The following is a description of a gene set: Genes down-regulated in dendritic cells: immature versus mature inhibitory infected with L. monocytogenes. from publication Popov A, Driesen J, Abdullah Z, Wickenhauser C, Beyer M, Debey-Pascher S, Saric T, Kummer S, Takikawa O, Domann E, Chakraborty T, Krönke M, Utermöhlen O, Schultze JL (PMID 18802101) studied in species Homo sapiens Myeloid dendritic cells (DC) and macrophages play an important role in pathogen sensing and antimicrobial defense. Recently we demonstrated that infection of human DC with intracellular bacterium Listeria monocytogenes (L.monocytogenes) leads to the induction of the immunoinhibitory enzyme indoleamine 2,3-dioxygenase (Popov et al., J Clin Invest, 2006), while in the previous studies L.monocytogenes infection was associated with a rather stimulatory DC phenotype. To clarify this discrepancy we performed comparative microarray analysis of immature mo-DC (immDC), mature stimulatory mo-DC (matDC) and mature inhibitory DC either stimulated with prostaglandin E2 (PGE2-DC) or infected with L.monocytogenes (infDC). Studying infection of human myeloid DC with Listeria monocytogenes, we found out, that infected DC are modified by the pathogen to express multiple inhibitory molecules, including indoleamine 2,3-dioxygenase (IDO), cyclooxygenase-2, interleukin 10 and CD25, which acts on DC as IL-2 scavenger. All these inhibitory molecules, expressed on regulatory DC (DCreg), are strictly TNF-dependent and are in concert suppressing T-cell responses. Moreover, only DCreg can efficiently control the number of intracellular listeria, mostly by IDO-mediated mechanisms and by other factors, remaining to be identified. Analyzing publicly acessible data of transcriptional changes in DC and macrophages, infected by various pathogens and parasites (GEO, GSE360), we noticed that infection of these cells with Mycobacterium tuberculosis causes transcriptional response, comparable with the one caused by listeria in human DC. In fact, granuloma in tuberculosis and listeriosis in vivo are enriched for myeloid DC and macrophages characterized by regulatory phenotype. In summary, regulatory myeloid DC and macrophages may play a dual role during life-threatening granulomatous infections, such as tuberculosis: on one hand, regulatory myeloid cells promote pathogen containment by efficiently killing intracellular bacteria, on the other hand these cells inhibit granuloma-associated T cells and thereby might be involved in the retention of TNF-controlled granuloma integrity protecting the host from granuloma break-down and pathogen dissemination. Human Gene Set: GSE9946_IMMATURE_VS_LISTERIA_INF_MATURE_DC_DN, and this is the list of marker genes: RDH5 (NCBI Gene Id 81991), HTR6, CDK5R2, RGR, EGFL6, VAMP7, KCNK13, MGST1, TPPP2, RTN4R (reticulon 4 receptor), SLC16A14, BCL2L14, FIBIN, PDE5A, MIR543, MYOF, TMEFF1, OSGEPL1 (O-sialoglycoprotein endopeptidase like 1), NUP160, SERPINB12, RGS18, FGF6, SLC35A2, HMGN3, THNSL2, TCEAL8, TMEM164, PROCA1 (protein interacting with cyclin A1), HOXC10, TBC1D5, SLC37A1, MESP1, TPI1, MRS2, PLXNB3, TRIM72, TNNT1, GEMIN8, MIR7-1, MICAL2, GYS2, RNF13 (ring finger protein 13), SCN11A, UIMC1, MIR1-1, DRAM2, FBXO4, GNG2, AOC3, ADGRG2, NHLRC1, FAM169A, MARCHF1, SSC4D, BTRC, CDH12, EEF1AKMT2, PAQR3, RAB3GAP2, ALG8, MIR653, FRMD3, GRB7, ISG20, AHDC1, CYFIP1, PSMB11, BTF3, ASB11, AMPH, IK, ASB2, LGI2, RBM15, CTH, RAD50, TMEM82 (NCBI Gene Id 388595), RPS14, PIK3AP1, PLA2G12B, BMP6, APOL6, KRTAP26-1, PABPC4, ESM1, GYPA, MTHFD2L, IFITM3, GPX2, RTKN, PTGS1, ENTPD1, HOXA9, POU2AF1, CYP2R1, MTREX, OXSM, CLCN1, C1QL4, CCDC184, COX20, IL22RA2, FER1L4, ALDH1L2, TMEM165, BCAP29, ADCYAP1, TRIM24, SLC35F1, ACE, VLDLR, CCDC141, SDC4, MRPL49, ASCC2, UPK3B, CENPC (NCBI Gene Id 1060), NRP1, CLU, PTGR3, KLHL23, SEC14L3, GPN1, USPL1, ASAH2, GAP43, RBPJ, SYNGAP1, CTHRC1, ARF6, SREK1IP1, CGA, IGF2BP1